The following is a description of a gene set: The directed, sodium-independent, movement of organic anions into, out of or within a cell, or between cells, by means of some agent such as a transporter or pore. species: Homo sapiens Human Gene Set: GOBP_SODIUM_INDEPENDENT_ORGANIC_ANION_TRANSPORT, and this is the list of marker genes: SLCO2B1, SLCO1B7 (solute carrier organic anion transporter family member 1B7 (putative)), SLC22A6, SLC22A9, MFSD10, SLCO4A1, SLCO1B1, SLCO6A1, SLCO4C1, SLCO1B3-SLCO1B7, SLCO3A1, SLCO1B3, SLCO2A1, SLCO5A1, SLCO1C1, SLCO1A2